Given this list of marker genes NBN, CHEK2 (checkpoint kinase 2), RAD51, CASP3, BRCA2 (NCBI Gene Id 82716), BLM, RAD9A, PCNA, PRKDC, STK3, MDM2, PARP1, RASSF1, ATR, MDC1, TRIM28, RAD52, CHEK1, CDC25C, ACTL6A, BRCA1, SMC3, SMC1A, HSF1, RIF1, TRAF6, YAP1, E2F1 (NCBI Gene Id 1869), TP53, RNF8, ATF2, FANCD2, BID (BH3 interacting domain death agonist), BAK1, TERF2, UPF1, APAF1, BAX, CDK5, TP73, ABL1, MRE11, MCPH1, CASP9, LATS1, KAT5, NABP2, DCLRE1C, H2AX, TP53BP1, EXO1, ATM, RAD50, CDKN2A, RAD17, here is a description of the gene set: DNA IR-double strand breaks and cellular response via ATM Human Gene Set: WP_DNA_IRDOUBLE_STRAND_BREAKS_AND_CELLULAR_RESPONSE_VIA_ATM studied in species Homo sapiens